Given this list of marker genes SUCLA2, CPT1C, TCIRG1, MT-ND4, MT-ND5, EDNRB, SNX10, ELOVL4, KPNA3, PLA2G6, MORC2, LAMA2, SOX10, EBP, MFN2, CWC27, ATP1A3, SLC33A1, ERCC4, ABCD1, RAB3GAP2, CLN8, SPG11 (SPG11 vesicle trafficking associated, spatacsin), COX6B1, KARS1, MT-CO3, MT-ATP6, UBAP1, ALS2, MT-CYB, SNF8, OSTM1, SCAPER, NEFL, RIPOR2, GJC2, ERCC6, NOTCH3, EMC1, WASHC5 (WASH complex subunit 5), MTMR2, EPM2A, SAMD12, NDUFS2, PRPH2, MPDU1, MFF, RAB3GAP1, TBC1D20, ABCA4, DNM1L, ITPR1 (inositol 1,4,5-trisphosphate receptor type 1), TYR (NCBI Gene Id 7299), PROM1, ERCC8, OPA1, STUB1, UCHL1, POMGNT1, DIAPH3, TIMM8A, MT-ND6, AAAS, SPG7, TNFSF11 (TNF superfamily member 11), FXN, HYCC1, TTPA, CYP27A1, MOGS, NDRG1, ZNHIT3, SH3TC2, OTOF, MT-ND2, HIKESHI, PLP1, DNAJC30, MT-ND1, STARD7 (StAR related lipid transfer domain containing 7), POGZ, GALC, SACS (NCBI Gene Id 26278), NDUFS4, YEATS2, SPTBN4, NHLRC1, PSAP, MT-CO1 (mitochondrially encoded cytochrome c oxidase I), MT-ND4L (mitochondrially encoded NADH:ubiquinone oxidoreductase core subunit 4L), RDH11, CLCN7, MECR, TBC1D24, LMNB1, ARSA, ATXN1, NMNAT1, RTN2, ARHGEF2 (NCBI Gene Id 9181), POLG (DNA polymerase gamma, catalytic subunit), ACOX1, PRPS1, RAB18 (NCBI Gene Id 22931), CNGB3, SEMA6B, MARCHF6, MYH3, SLC25A22, here is a description of the gene set: Abnormal brain-evoked potentials Any anomaly of brain-evoked potentials, defined as potentials generated by exteroceptive stimuli reflect synchronized activity by neuronal and axonal groups in the central nervous system (CNS) resulting from the arrival of nerve impulses after stimulation of a peripheral nerve or its receptors. Depending on the type of stimulus, evoked potentials are categorized as visual (VEP), auditory (AEP), or somatosensory (SSEP). Motor evoked potentials (MEP) occur when the brain's motor area is stimulated. They result from the activation of a sufficient number of motor units. Human Gene Set: HP_ABNORMAL_BRAIN_EVOKED_POTENTIALS studied in species Homo sapiens